The following is a description of a gene set: studied in species Homo sapiens Human Gene Set: HP_ALOBAR_HOLOPROSENCEPHALY A type of holoprosencephaly characterized by the presence of a single ventricle and no separation of the cerebral hemisphere. The single midline ventricle is often greatly enlarged. Alobar holoprosencephaly, and this is the list of marker genes: PTCH1, STAG2, ZIC2, KMT2D, FGFR1, KDM6A, PLCH1, SIX3, GLI2